Given this list of marker genes HCP5, HLA-DMB (NCBI Gene Id 3109), VAMP3, TRIB2, IFNGR1, IMPA1, GLS, YTHDF3, GAS7, KLHL18, EFCAB14, FCGRT, CLCN4, IFT20, CYTH1, LAMA5, TNFAIP3, ITPR1, KMO, FEZ2, POU4F1, KPNA6, RAG1, CYLD, YIPF1 (Yip1 domain family member 1), DHRS7, H2AC6, CDK12, STAT6, CXCL2, C6orf62, RGS16, DOCK4, ZFYVE16, HLX, FCMR, LINC01138, GORASP1 (golgi reassembly stacking protein 1), RIPOR2, MTSS1, H3C4, ARL6IP5, IDH1, HCK, MORC3, MYO1C, STX12, TMT1A, PRKCB, ADH1A, GH1, RELB, LDOC1, STX7, ABLIM1, CSNK1D, ATAD2B, MX2, KLF7, PATZ1, RASSF8, GRSF1, TERF2IP, KRT35, F13A1, ZFP36, SIN3B (NCBI Gene Id 23309), OPTN, GADD45G, MIA3, ANKRD17, VDR, RNF14, NTS, H2BC5, RGS6, ZKSCAN4, ARHGAP32, TLR2, CEBPD, CAND2, RPS6KA2, VAMP4, UBL3, ABCB4, ALG13 (NCBI Gene Id 79868), DNAJC16, PBXIP1, TFE3, MAGI2, GCA, AREL1, PCMTD2 (protein-L-isoaspartate (D-aspartate) O-methyltransferase domain containing 2), CLCN6, MIOS, SETBP1, RGL2, FBXL5, ZNF202, SERINC1, H2BC21, RABGAP1, PNISR, RBM19, SMAD7 (SMAD family member 7), TOR1AIP1, MTMR3, PLEC, ZEB2, HEXIM1 (NCBI Gene Id 10614), JADE2, FAM8A1, PPP1R2, SATB1, DAPK1, ACSM3, MXI1, ASAH1, ARAP2, ATG14, PSEN2, CSK, RHOBTB1, ZNF195 (NCBI Gene Id 7748), RYK, JRKL, KDM6B, SENP6, TRIM13, MGLL, HMHB1, GABBR1, RNF41, SETX, EVI5, CRIM1, TRIM22, SPTA1, CXCL3 (NCBI Gene Id 2921), HBP1, CD55, AKAP11, CD69, BLCAP, ZNF32, VNN2, RNASE2, IFRD1, SRSF8, NFKBIE (NCBI Gene Id 4794), HABP4, PSEN1, RHOH, TMSB4Y, OAS2, ABCG1, MAP3K8, MOB4, DOCK9, H2BC12, TOGARAM1, SERPINF1, SPINT2, PTPN2, GALC, MKNK1, PHF21A, RPS6KA1, BTBD3, LY75, IL16, PPP1R16B, SLC7A6, LYST, TRAF6, RNASE6 (ribonuclease A family member 6), RNF13, ESYT1, RFX5, LYZ, ST6GAL1, HHEX (hematopoietically expressed homeobox), FOLR2, CD19, OAS1, TLE1, PDIA5, HDAC9, RNF11, LRP10, IL4R, ZDHHC17, MPPED2, HLA-E, N4BP2L2, SBSPON (somatomedin B and thrombospondin type 1 domain containing), PSD4, BAZ2B, BAZ2A, here is a description of the gene set: Genes down-regulated after poly(IC) injection: CD8A dendritic cells versus NK cells. studied in species Homo sapiens The injection of the pathogen-associated molecular pattern Polyinosinic-polycytidylic acid (poly(I:C)) leads to the activation of various immune cells, including dendritic cells (DCs) and Natural Killer (NK) cells. This activation is due to different innate cytokines produced early after injection, in particular IFN-I. The objective of the study was to compare the pattern of expression of IFN-I stimulated genes between DC and NK cells. The project focused on a specific subset of conventional DC, CD8a DC, which responsiveness to IFN-I determines the capacity to activate CD8 T cells by cross-presentation of exogenous antigens. To identify the responses to IFN-I selectively induced in CD8a+ DC, we compared their gene expression profile to that of NK cells, using gene chips, before and after poly(I:C) stimulation. from publication Baranek T, Manh TP, Alexandre Y, Maqbool MA, Cabeza JZ, Tomasello E, Crozat K, Bessou G, Zucchini N, Robbins SH, Vivier E, Kalinke U, Ferrier P, Dalod M (PMID 23084923) Human Gene Set: GSE39556_CD8A_DC_VS_NK_CELL_MOUSE_3H_POST_POLYIC_INJ_DN